Given this list of marker genes ACVR1, TGFBR2, TGFBR3, AMHR2, LTBP4, TGFBR3L, ACVRL1, TGFBR1, BMPR2, BMPR1A, BMPR1B, LTBP1, here is a description of the gene set: Combining with a transforming growth factor beta (TGFbeta) and transmitting the signal from one side of the membrane to the other to initiate a change in cell activity by catalysis of the reaction: ATP protein serine = ADP + protein serine phosphate, and ATP + protein threonine = ADP + protein threonine phosphate. Human Gene Set: GOMF_TRANSFORMING_GROWTH_FACTOR_BETA_RECEPTOR_ACTIVITY species: Homo sapiens